The following is a description of a gene set: The directed movement of cobalt (Co2+) ions into, out of or within a cell, or between cells, by means of some agent such as a transporter or pore. Mouse Gene Set: GOBP_COBALT_ION_TRANSPORT species: Mus musculus, and this is the list of marker genes: Slc30a5, Slc11a2, Slc39a8, Tcn2, Mmgt1, Slc41a2, Mmgt2, Cblif